Given this list of marker genes EXOC1, KIFAP3, SLC2A4, TUBB4B, AKT1, RALGAPB, TUBA1C, STXBP3, TUBA1A, TBC1D4, RAB10, STX4 (syntaxin 4), TUBB1, EXOC6, YWHAZ, EXOC7, YWHAG, PRKAG1, CALM1, PRKAG3, VAMP2, EXOC3, RAB8A, RAB11A, RAC1, TBC1D1, EXOC8, SFN, ASPSCR1, ACTG1, YWHAB, MYH9 (myosin heavy chain 9), TUBA4A, EXOC5, PRKAG2, TUBB3, KIF3B, AKT2, C2CD5, TUBA3D, TUBA3E, TUBAL3, YWHAE, PRKAB1, TUBB4A, TUBB2A, TUBA3C, RAB4A, TUBA8, SNAP23, RAB14, RALGAPA2, TUBB8, RHOQ, EXOC2, TUBB2B, TUBA4B, KIF3A, MYO5A, MYO1C, EXOC4, YWHAQ, TUBA1B, RAB13, YWHAH (tyrosine 3-monooxygenase/tryptophan 5-monooxygenase activation protein eta), TUBB8B, LNPEP, PRKAA2, RALA, PRKAB2, ACTB, TUBB6, here is a description of the gene set: species: Homo sapiens In adipocytes and myocytes insulin signaling causes intracellular vesicles carrying the GLUT4 (SLC2A4) glucose transporter to translocate to the plasma membrane, allowing the cells to take up glucose from the bloodstream. In myocytes muscle contraction alone can also cause translocation of GLUT4.<br>Though the entire pathway leading to GLUT4 translocation has not been elucidated, several steps are known. Insulin activates the kinases AKT1 and AKT2. Muscle contraction activates the kinase AMPK-alpha2 and possibly also AKT. AKT2 and, to a lesser extent, AKT1 phosphorylate the RAB GTPase activators TBC1D1 and TBC1D4, causing them to bind 14-3-3 proteins and lose GTPase activation activity. As a result RAB proteins (probably RAB8A, RAB10, RAB14 and possibly RAB13) accumulate GTP. The connection between RAB:GTP and vesicle translocation is unknown but may involve recruitment and activation of myosins.<br>Myosins 1C, 2A, 2B, 5A, 5B have all been shown to play a role in translocating GLUT4 vesicles near the periphery of the cell. Following docking at the plasma membrane the vesicles fuse with the plasma membrane in a process that depends on interaction between VAMP2 on the vesicle and SNAP23 and SYNTAXIN-4 at the plasma membrane. Reactome Pathway: Translocation of SLC2A4 (GLUT4) to the plasma membrane part of: Membrane Trafficking